Given this list of marker genes PRPF40B, PTX3, CLINT1, TCP11L2, IDS, SLC30A9, CAV1, OSTM1, NFYB, ANKRD28, FEM1C, SNX5, VWA2, PCDHB4 (protocadherin beta 4), SYDE2, CYP26B1, KIT, FBN1, NDNF, DCBLD2, GALNT13, STK17B, EPN2 (NCBI Gene Id 22905), PTP4A1, TBC1D8B (TBC1 domain family member 8B), SLC5A12, ZSWIM5, HDLBP, SWSAP1, CLIP4, PDE4D, PLPPR1, ATP8B1, POGZ, APPL1, C3orf80, IRAK4, ANGPT2, TNFAIP6, SENP6, MTR, PELI1, FBXO30, POPDC3, BLCAP, PLD1, FAM174A, DMD, PDCD6IP, PHIP, SPOCK2, SH3KBP1, CALM1, SLC2A13, SPAG9, MED28, SSH1, PLAT, FZD3, THSD7B, VPS37A, VHL, MAN1A1, ULK4, TBL1XR1, UBE2V2 (ubiquitin conjugating enzyme E2 V2), C8orf34, HSPH1, SLC12A2 (solute carrier family 12 member 2), MRE11, ZNF831, RANGRF, INO80D, JPH1, C14orf28, C7orf57, QSER1, ZNF503, MYBL1, TNKS2, VGLL3, VCL, PRPSAP2, RIC1, NR1D2, ANO2, IRF2BP1, DCUN1D1, GNAL, GBP5, ITFG1, LPP, KCNJ13, FAM13B, DLG1, C5orf47, CDC73, DYRK2, WDR12, POLI, IGFBP3, CCSER1, HOXB2, CARMIL1, NOTUM, CAPN10, TRRAP, JRK, TAFA1, RNF217, USP38, BEND2, NEK7, PLXND1, BAAT, CHUK, LHFPL6, LRRCC1, ARID1A, SHCBP1, HIRIP3, GOPC, ANGEL2, ITGA6, ZNF292, SS18, LPCAT1, DPP10, CLVS2, NCKAP5, PRDM1, ZFYVE16, LRFN4, ISCA1, RUNDC3B, CXADR, EN2, PRELID2, SLC4A7, DLGAP1, ANKIB1 (NCBI Gene Id 54467), IFNG, TP63, CCDC68, ACTC1, STK26, CHD6, CTCFL, PCGF3, PPM1B, SDHAF4, RIMBP2, POGLUT2, TBC1D15, AHCTF1, ARHGAP6, MTMR10, GJA3, USP25, SCN1A (sodium voltage-gated channel alpha subunit 1), GK5, EPAS1, USP1, WDR44, C21orf91, SEC63, SERPINB13, SLC28A3, RPS6KA5, XRN1, ZNF239, PIK3CB, DNAJC25, MYL12A, WDR26, GSKIP, PUM2, MRPL22, SERBP1, ALCAM, YAF2, CADM3, AHR, ZDHHC17, MANEA, ZBTB34, KCNS3, KRT80, EDNRB, RADX, REST, NPAS4, NR2C1, FDX1, HHIP, MYRIP, IRX2, ELOC, SORBS2 (sorbin and SH3 domain containing 2), MBNL3, SFMBT1, ESYT2, RASSF3, E2F8, SUCO, HNRNPH3, RIC8B, SNX6, KIF14, UBR3, ITGAV, ZNF471, ENTPD1, PLAAT3, RBM7 (RNA binding motif protein 7), CERT1, OLFM3, ASAP2, CLIC4, DUSP18, MET, NEXMIF, PEDS1, RAD50, PHLDA1, LIN9, SCARB2, TMPRSS12, FHIP2A, PRKCA, TAF8, TIAM1, OTUD4, TNKS1BP1, ELAVL4, FAM76B, CDKL5, FBXO8, COMMD3-BMI1, GNG12, SNRPB, CXCL14, CTTNBP2, C1QTNF3, DEPDC1B, TAB3, RP2, RFX7 (regulatory factor X7), ARMC8 (armadillo repeat containing 8), DCX (doublecortin), CTBS, TMEM220, BCOR, CWC25, CDH12, RIOX2, ZBTB21, SIRPB1 (signal regulatory protein beta 1), CBR4, MGAT4A, HLA-DMA, SLCO4C1, BDP1, ALS2, TRIP4, PRKAA2, PTK2, UGDH, KIAA0586, TMX3, PIK3CA, GNAI1, CEPT1 (NCBI Gene Id 10390), SELENOK, TENM1, HOXD8, NFE2L2, PIP4P2, MAP7, SELENOT, ZNF507, EPHA3, ALKAL1, IGF1, CASP1, TNFAIP3, PCMTD1, ZNF543 (NCBI Gene Id 125919), PGM2L1, IQCJ, PRKAR2B, LCORL, PRDM11, BTBD1, FGF12, CNEP1R1, RBM41, BCL10, ATXN7, DDX5, CCDC47, PPP1CB, ZNF513, SECISBP2L, VSX1, ITGB8, MED14, CREBRF, HECW2, FIGN, COBLL1 (cordon-bleu WH2 repeat protein like 1), LUZP2, PKN2, VPS50, ANKRD12, NCAPD3, PSAT1, ZSCAN29 (NCBI Gene Id 146050), USP9X, WWTR1, ARGLU1, VPS54, ZNF713, RAB3C, KCNK1, PLAUR, E2F7, OSBPL6, NDC1, MAGOH, TUBE1, PSIP1, ERBIN, ATP6V0C, SLC13A1, HAPLN1, SPIRE1, SATB1, AMMECR1L, TPP2, ZBTB37, MTX3, ADIPOR2, MBTD1, CFAP97, MDM1, TMEM26, DYNC1I2, SMIM17, ITGA9, IPMK, TMEM64, NCAM2, ZDHHC21, MSRB3, TTPA, CWC22, ARL4C, NR2C2, LIN54, SRGAP1, FOXN2, IL20RA, ATXN7L2, ZNF385B, YOD1, FRMD6, ADAMTS19, KAT6A, PGM3, RHBDD1, ZC3H6, MIB1, STT3A, HHEX, USP24, RB1CC1, SUMO2, ICE1, RORA, DCAF12, GLMN, MATCAP2, CDON, APOL6, HMCN1, MAPK14, TDO2, LRP5, EDIL3, ZBTB41, FGF7, GNA13, STXBP4, ANKRD40, HELQ, ARHGEF38, PKNOX1, ERI1, MFSD14B, CCDC146, ATP2B1, OGT, ABHD13, TFDP1, POLK, GLYATL3, MTPN, HPS4, PDE4B, STOX1, LRP12, TMEM248, IER5L, STC1, SLC1A2, APLN (NCBI Gene Id 8862), VMP1, TSHZ3, CACNA2D1 (calcium voltage-gated channel auxiliary subunit alpha2delta 1), RORC, KIF23, H3-3B, NT5C1B-RDH14, MFSD9, JAM3, RNH1, CEP57L1, BLOC1S6, QKI, PGM2, GPR15, SKIL (NCBI Gene Id 6498), NPNT, BOD1L1, MAT2A, EVI2B, NFAT5, YES1, URB1, SUB1, LIN7A, YTHDF3, MEGF9, LEPROT, PLPPR5, HERC3, RRM2B, ELAVL2, GDAP2, GREB1, BMP4, EIF5A2 (NCBI Gene Id 57114), RAP1A, ATAD1, PIK3C2A, SLC30A6, ACTR3, STIM2, DBF4, MLH3, ATP1B1, ZFAND4, TBC1D23, ZNF829, ODF2L, FRS2 (fibroblast growth factor receptor substrate 2), LHX1, SELENOI, UBE2D1, KCNH5, EVC2, GOLM2, RBM24, NR4A3, TOGARAM1, NENF, GALNT18, FER, BTAF1, EWSR1, CREM, PGRMC2, MED17, GJB6, SENP7, TOPORS, TCEA1, TMEM120B, C3orf70, MMAA, RGS4, SHISA5, ERP44, RTN4RL1, FGF13, MCMBP, RNF111, SFXN1, CAMSAP2, ZNF417, RBMS1, ALG10B, CD36, MICAL2, C2CD5, CABP7, MFHAS1, HSD11B1, SSR3, AGAP1, TOX2, ADGRL3, DIXDC1, ANKRD62, UBL3, DGKH, GRM5, SLC20A2, SAMD12, SYTL4, ZFPM2, MCU, SV2B, ADGRB3, EIF3J, YY1, DENND1B, MYO1B, IQCK, BVES, PAIP1, NET1, IGF2BP3, SMIM15, ZNF10, VAV3, ZXDB, REV3L, TMEM106B, SLC33A1, ADPGK, UTRN, PWWP3B, RAB27B, DLL4, SGCE, BRWD3, VASN, NFATC3, ATP13A3, PHTF2, LRRC18, TRAF3IP2, GUCY1B1, KAT6B, N4BP2, CEP44, YAP1, BMX, NRARP, TWSG1, TMTC1, FAM91A1, PNO1, DCN, COPB1, PPRC1, TENT4B (NCBI Gene Id 64282), PRDM16, INTS2, FGF2, CASK, SGPP1, GUCY1A2, TLCD4, EIF3A, CCPG1, CADM2 (cell adhesion molecule 2), NPAT, LAMC1, MAP4K5, NHLH2, RPAP3, TNS1, CILK1, CDH9, CACNB4, ANKRD13D, SIVA1, ARFRP1, CEP120, C20orf203, SACM1L, GPR137C, CBLB, CETN3, CPNE8, GRIA4, ETNK1, MAP4K3, BRD1, SUZ12, SKP2, SLITRK4, ZNF587, TDG, PLEKHA3, ABHD3, ATF1, FSD1L, TBX5 (T-box transcription factor 5), PPP3CB, ZBTB11, PMP22, TMEM108, OGFRL1, EXOC5, DBR1, RUNX1T1, SPTSSB, POU2F1, SGIP1, MED13, KLHL15, TNIP2, LACTB, BPNT2, KCNJ16, WDR43, SH3GL3, SLC6A14, ZXDA, PRKRA, PDIK1L, ARHGEF6, SCMH1, ZNF599, C1orf35, CCNG2, EPPIN, ARID1B, TTC8, BARD1, TNFSF10, HS2ST1, NUP58, DR1, RFK, LDLRAD4, GABPA, DNASE2B, SLC25A32, SMCHD1, RIGI, ZC3H12B, SLC25A24, DLC1, ASB7, ERLIN1, MAP3K2, TRIM2, HLTF (helicase like transcription factor), ASH1L, SLC11A2, G3BP2, PTPRE, BRIP1, CNTLN, WWC3, CYFIP1, G2E3, ZCCHC14, FHIT, SVIP, TOM1L1, EIF2AK3, MINDY3, KLHL4, ZFC3H1, AP3M1, KCNA4, CDKN2AIPNL, DNAI4, RPGR, CHIC1, MYO10, RGMB, SLC25A12, SLC7A11, FGD6, TMEM33, ONECUT2, LATS1, MYLIP, PUM1, CYLD, SF3B1, CC2D2A, RFC5, ERO1B, NDFIP2, GRK2, SLC30A7, PXYLP1, TRANK1, ANKS1B, CDC42SE2, MMP16 (NCBI Gene Id 84257), PHC1, BMPR1A, SLC36A4, SEH1L, SMAD2, XPO4, MTFR1, CAPN7, CREBL2 (NCBI Gene Id 1389), PLEKHG4, ADAMTS5, ZNF652, SCN7A, SLC12A5, ADAMTS1, CREB1, RAB6D, ITPR2, SAMD13, TANC2, ALDH1A3, SUN1, HERPUD2, ACAP2, SERPINB10, TOR1A, XPOT, TMEM245, LSM8, PGR (NCBI Gene Id 5241), MKLN1, PALLD, FBXL3, EXO1, TMEM74, TACR2, LRP1B, KRR1, ARG1, SLK, NUCKS1, MAP2, SNX3, RAB11A, CEP290, IPO7 (importin 7), RPS6KA6, HNF4G, MAMDC2, MSTN, C1D, TCF21 (transcription factor 21), FRZB, SMARCAD1, ENAH, CCDC71L, IDE, LMO7, DTNA, MED12L, ARL5A, WDR64, SLC49A4, FRAS1, DYNC1I1, NOG, UNKL, ZNF736, GYPA, TET2, RHOA, ISG20L2, MZT1, ITGA4, LSG1, SLC30A4, HOOK3, ZSWIM6, FGL2, TRMT9B, PLXDC2, MACF1, here is a description of the gene set: Human Gene Set: MIR340_5P Genes predicted to be targets of miRBase v22 microRNA hsa-miR-340-5p in miRDB v6.0 with MirTarget v4 prediction scores > 80 (high confidence targets). studied in species Homo sapiens from publication Chen Y, Wang X (PMID 31504780)